Given this list of marker genes HTR2A, RHOJ, KCNJ2, NCKAP5, YPEL4, COL4A4, ESR2, ACTA2, PTPRR, SYT3, TCAM1P (testicular cell adhesion molecule 1, pseudogene), NPY2R, RLN2, UCP1, COL1A1, CALY, IGF1, KCNMB2, TMEM255A, ANK3, SUSD4, NOL3, INSYN2B, CFAP65, TAL2, C11orf87 (chromosome 11 open reading frame 87), SYT1, ZEB2, KCNA4, IGSF3, COL4A3, PLAT, SCML4, MCHR1, here is a description of the gene set: studied in species Mus musculus Genes with intermediate-CpG-density promoters (ICP) bearing the bivalent trimethylation marks at H3K4 (H3K4me3) and H3K27 (H3K27me3) in MCV6 cells (embryonic fibroblasts trapped in a differentiated state). Human Gene Set: MIKKELSEN_MCV6_ICP_WITH_H3K4ME3_AND_H3K27ME3 Somatic cells can be reprogrammed to a pluripotent state through the ectopic expression of defined transcription factors. Understanding the mechanism and kinetics of this transformation may shed light on the nature of developmental potency and suggest strategies with improved efficiency or safety. Here we report an integrative genomic analysis of reprogramming of mouse fibroblasts and B lymphocytes. Lineage-committed cells show a complex response to the ectopic expression involving induction of genes downstream of individual reprogramming factors. Fully reprogrammed cells show gene expression and epigenetic states that are highly similar to embryonic stem cells. In contrast, stable partially reprogrammed cell lines show reactivation of a distinctive subset of stem-cell-related genes, incomplete repression of lineage-specifying transcription factors, and DNA hypermethylation at pluripotency-related loci. These observations suggest that some cells may become trapped in partially reprogrammed states owing to incomplete repression of transcription factors, and that DNA de-methylation is an inefficient step in the transition to pluripotency. We demonstrate that RNA inhibition of transcription factors can facilitate reprogramming, and that treatment with DNA methyltransferase inhibitors can improve the overall efficiency of the reprogramming process. from publication Mikkelsen TS, Hanna J, Zhang X, Ku M, Wernig M, Schorderet P, Bernstein BE, Jaenisch R, Lander ES, Meissner A (PMID 18509334)